Given this list of marker genes VTN, COL1A2, TGFB1, SDC3, ITGB5, SDC4, FGF2, TRAPPC4, ITGA2, ACTN1, COL1A1, ITGA6, COL5A3, COL5A1, THBS1, SDC2, ITGB1, FN1 (NCBI Gene Id 2335), ITGAV (integrin subunit alpha V), TNC, ITGB3, COL3A1, CASK, COL5A2, ITGB4, SDC1, PRKCA, here is a description of the gene set: species: Homo sapiens Human Gene Set: REACTOME_SYNDECAN_INTERACTIONS Syndecan interactions